Given this list of marker genes CHRNA7 (cholinergic receptor nicotinic alpha 7 subunit), ZNF804A, RPS6KA5 (NCBI Gene Id 9252), CDKL5, ARHGEF15, NRXN1 (neurexin 1), INA, MYH10, INSR, HOMER1, PPP1R9B, NPTX1, PICK1, CRIPT, PRICKLE1, GAP43, VPS35, SLITRK3, DBN1, INS, TREM2, TRIM47, NEURL1 (NCBI Gene Id 9148), HIP1R (huntingtin interacting protein 1 related), ITGB3, NRCAM, NUMBL, CAPRIN2, FZD9, ADAM10, ABHD17C, SHANK3, ENAH, FGFR1, SLC7A11, EPHB3, DNAJA3, MTMR2, ASIC2, ETV5, RER1, CSMD2, LRRC4, HTR4, ARC, CDK5R1, LZTS1, PPFIA2, WNT5A, MARK1, SYNDIG1, CBLN1, CC2D1A, CHRNB1 (NCBI Gene Id 1140), LRP4, GPHN, CYFIP2, ARHGAP39, PUM2, ZDHHC15, WASL, RTN4, RAPSN, RTN4R, CUX2, SRCIN1, NEDD8, C1QL2 (NCBI Gene Id 165257), TANC1, CFL1, APOE (apolipoprotein E), LAMA5, ARF4, ZDHHC2, PSEN1, WASF2, CHMP2B, AKT1 (AKT serine/threonine kinase 1), ASIC1, ARHGAP12, POTEI, LRRC4B, NTRK3, TANC2, NGEF, NEDD9, ABI3, DOCK10, SHANK1 (SH3 and multiple ankyrin repeat domains 1, NCBI Gene Id 50944), SIPA1L1, SEMA3F, ARHGAP22, GHRL, NOS1AP, NEFH, GDNF, ABHD17B, DLG1, EPHA7, ITGA3, C1QL3 (complement C1q like 3), DIP2A, ACTN1, HDAC6, FYN, NCKIPSD, ZDHHC8, BAIAP2, NLGN1, ABL1, SH3GL2, IL1RAP, SPTBN2, S1PR2, NLGN3, SSH1, EFNA1, INSYN1, CTTN, ELMO1, ZNF365, ARF6, IL1RAPL1, NF1, ACTBL2, GRIN2B, SHISA6, MIR30B, KIF2C, ARF1, ARHGEF9, ARMCX5-GPRASP2 (ARMCX5-GPRASP2 readthrough), PTK2B (NCBI Gene Id 5748), EEF2K, RAC1, COLQ, DISC1, FRRS1L, CNTNAP1, LRFN1, ACTG1 (NCBI Gene Id 71), DLG5, CDC42, PTPRD, GIT1, CPNE6, CDK5, ARHGAP33, FARP1, TMEM108, PDLIM5, CRKL, NRP1, WNT7A, CTNND2, RELN, NTNG2, LGMN, ITSN1, ZDHHC12, LRP8, LZTS3, ZMYND8, UBE2M, PLPPR4, GRID2, POTEKP, POTEJ, MUSK, PTPN1, SIGMAR1, CASKIN1, DOCK1, NRP2, GRID1, DVL1, PTEN, CRK, PTPRS, SENP1, ACTB, DBNL, EZR, GLRB, CRMP1, LRFN4, DOCK4, LRFN2, POTEE, EPHB2, ABHD17A, DHX36, MESD, NRXN2, UBE3B, CAPRIN1, APP (amyloid beta precursor protein), DTNBP1, CAMK2B, SLC30A1, CDH2 (cadherin 2), DLG4, ABI2, LRRK2, NEFL, CNKSR2, MAP1B, RAC3, RHOG, GHSR, CARMIL3, DOK7, KIF1A, STAU2, ACTN2, LATS1, SYNGAP1, ARHGAP44, LHFPL4, LILRB2 (leukocyte immunoglobulin like receptor B2), POTEF, FNTA, SEMA4C, SLC12A5, SHISA7, GNA13, ITPKA, PAFAH1B1, OPHN1, NECTIN3, IGF1R, NAE1, NLGN2, LRRTM2, CHRDL1, ACTL8, STK38, PAK3, EPHB1, GPRASP3, EPHA4, FCGR2B, PRNP, here is a description of the gene set: studied in species Homo sapiens A process that is carried out at the cellular level which results in the assembly, arrangement of constituent parts, or disassembly of a postsynapse. Human Gene Set: GOBP_POSTSYNAPSE_ORGANIZATION